Given this list of marker genes Mexis, Gm12480, Vma21-ps, 4930522O17Rik, Gm12470, Fktn, Gm12468, Gm12477, Gm24177, Tal2, Nipsnap3b, Abca1, Or13c3, Cct3-ps1, Gm12495, n-R5s185, Or13c25, Tpt1-ps2, Gm12496, Smc2os, 1700060J05Rik, Slc44a1, Or13f5, Lexis1, Rps15a-ps8, Smc2 (NCBI Gene Id 67947), Tmem38b, Fsd1l, Tmc4-ps, Gm12466, Gm12479 (predicted gene 12479), Nipsnap3a, C630028M04Rik, Or13d1, Gm12482, Toporsl, Gm23745, Gm12509 (predicted gene 12509), Or13c9, Gm12467, Gm12461, Or13c10-ps1, Zfp462, Gm12475, here is a description of the gene set: Mouse Gene Set: chr4B2 studied in species Mus musculus